The following is a description of a gene set: Mouse Gene Set: chr8A1 studied in species Mus musculus, and this is the list of marker genes: Fbxo25, Gm16553, Angpt2, Retn, Gm5608, Stxbp2, Gm39132, Clec4g, Lrrc8e, Gm25665, Gm15366, Gm2814, Arglu1, Spaca7b, Gm7600, Cd209d, Camsap3, Gm18991, Gm7706, Gm6070, Gm7397, Gm24231, 4833411C07Rik, Defa-ps12, Mcemp1, Mir7238, Gm39121, Gm31463, Irs2, Gm10060, Gm7389, Gm35392, Gm7346, Gm15358, Cd209g, Gm17149, Gm10699, Mcoln1 (mucolipin 1), Rprl3, Gm10067, Lig4, Gm39129, Gm7506, Gm44785, Gm5739, Gm7461, Gm9457, 4933439N14Rik, Rps16-ps3, Elavl1, Gm3160, Gm17023, Arhgef10, Insr, Gm32540, Xab2, Gm30954, 4930453L07Rik, Erich1, Vmn2r-ps88, Atp11a, Champ1, Gm2676, Saxo5, Spag11b, Gm35453, D530014G21Rik, Gm31343, Gm6410, Pex11g, Gm25278, Rab20, n-R5s122, Defb40 (defensin beta 40), Gm20778, Defa-ps13, Gm16425, Defb4, Gm15419, Tfdp1, Prr36, Gas6, Myom2, Kbtbd11, Tdrp (testis development related protein), 5330413D20Rik, 1700029H14Rik, Gm33326, 2900027M19Rik, Gm7676 (predicted gene 7676), Gm40466, Gm7669 (predicted gene 7669), Gm17215, Lamp1, Gm31401, 4921522P10Rik, 2810030D12Rik, Timm44, Arhgef7, Cd209a, Defb12, 9530052E02Rik, Cd209c, 1700014L14Rik, Evi5l (NCBI Gene Id 76450), Gm45224, Gm35998, Gm44717, Mir9768, Gm25014, Gm16589, Csmd1, Defb3, Gm7760, Defa-ps15, 4933430N04Rik, Potefam3f, F7, Semp2l2a, Mcf2l, Cfap97d2, Col4a2 (NCBI Gene Id 12827), 1700128E19Rik, Gm6334, Abhd13, Gm2734, Gm15348, Gm45420, Defb37, Col4a1, Ing1, Gm25763, Grtp1, Sox1, Leat1, Gm16350, Gm18393, Defa-ps14, Tubgcp3, B020031H02Rik, Defb6, Cln8, Gm15351, Cars2, Gm7407, Trappc5, Defb38, Cers4, Gm7434, Pnpla6 (NCBI Gene Id 50767), Sox1ot, Gm21811, Gm16347, Rpl21-ps14 (NCBI Gene Id 674403), D630011A20Rik, Cd209f, Gm7381, Selenot-ps, Dcun1d2, F10, Gm39128, 3110080E11Rik, Mcph1, Gm26184, Tmco3, Gm25169, Atp4b, Ctxn1, Rpl19-ps11, Shcbp1, Gm33175, Gm45231, Grk1, E230013L22Rik, Tex29, Tnfsf13b, Xkr5, Cdc16, Defb39 (NCBI Gene Id 360214), 9530085L11Rik, Gm7128, Rps23-ps2, Gm15418, Tgfbr3l, Pet100, 4930435N07Rik, Gm6524, Gm2448, Gm20786, Defb5, Slc10a2, Naxd, Tmem255b, Mir1968, Mir3106, Defb7, Gm7451, B830042I05Rik, Mir7065, Pcp2, Zfp958 (zinc finger protein 958), Gm31135, 4932443L11Rik, Pcid2, Nalf1, Snapc2, Gm44788, Cd209b (CD209b antigen), Defb34, Rasa3 (NCBI Gene Id 97473), Adprhl1, Upf3a, Map2k7, Ankrd10 (NCBI Gene Id 74590), Gm39139, Gm15352, Gm24288, Gm7562, Ccl25, 4931415C17Rik, Gm15350, Agpat5, Gm24698, Zfp358, Gm5605, Coprs, 5830468F06Rik, Spag11a, Potefam3e, Fcer2a, Defb14, Gm16725, Dlgap2, Arhgef18, Rps23rg1, 4930465I24Rik, Fcor, BB014433, Gm18210, Mir7654, E330037G11Rik, Spaca7, Efnb2, Cul4a, Gm6483, Gm35934, Defb46, Gm5907, Gm20100, Proz, Myo16, Gpi-ps, Vmn2r-ps89, C030037F17Rik, Cd209e, E230020D15Rik, Gm24469, Defb8, Gm6426